Given this list of marker genes CEBPA, AGMAT, ARG1, ASL, SLC25A2, OTC, SLC25A15, PKD1, FH, CYP2C9, SEC63, ARG2, ASS1, NR1H4, NAGS, CPS1, here is a description of the gene set: species: Homo sapiens Human Gene Set: GOBP_NITROGEN_CYCLE_METABOLIC_PROCESS A nitrogen compound metabolic process that contributes to the nitrogen cycle. The nitrogen cycle is a series of metabolic pathways by which nitrogen is converted between various forms and redox states; it encompasses pathways in which nitrogen is acted upon directly, such as nitrification, denitrification, nitrogen fixation, and mineralization.